The following is a description of a gene set: species: Homo sapiens Human Gene Set: GSE21774_CD62L_POS_CD56_DIM_VS_CD62L_NEG_CD56_DIM_NK_CELL_DN Human Natural Killer (NK) cells comprise two main subsets, CD56bright and CD56dim cells, that differ in function, phenotype and tissue localization. To further dissect the heterogeneity of CD56dim cells, we have performed transcriptome analysis and functional ex vivo characterization of human NK cell subsets according to the expression of markers related to differentiation, migration or competence. Here, we show for the first time that the ability to respond to cytokines or to activating receptors is mutually exclusive in almost all NK cells with the exception of CD56dim CD62L+ cells. Indeed, only these cells combine the ability to produce interferon (IFN)-gamma after cytokines and proliferate in vivo during viral infection with the capacity to kill and produce cytokines upon engagement of activating receptors. Therefore, CD56dim CD62L+ cells represent a unique subset of polyfunctional NK cells. Ex vivo analysis of their function, phenotype, telomere length, frequencies during ageing as well as transfer experiments of NK cell subsets into immunodeficient mice suggest that CD56dim CD62L+ cells represent an intermediate stage of NK cell maturation, which after restimulation can accomplish multiple tasks and further develop into terminally differentiated effectors. Genes down-regulated in SELL dim NK cells: NCAM1+ versus NCAM1-. from publication Juelke K, Killig M, Luetke-Eversloh M, Parente E, Gruen J, Morandi B, Ferlazzo G, Thiel A, Schmitt-Knosalla I, Romagnani C (PMID 20505160), and this is the list of marker genes: ELANE, S100A11, OLR1, EXTL1, TDRD9, EXOSC5, NCF1, TOR3A, MBOAT1, DEUP1 (NCBI Gene Id 159989), PI16, ANXA3, MRGPRF, SPNS3, LRG1, SRP68, SNTB1, TBC1D2, ATP6V0C, TRIM45, KRTAP11-1, CDS1, C19orf38, CCR2, GRIA3, STX7, UBTD1, NAALADL2, H6PD, DDO, TREM1, MRAP, DAAM2, CPVL, SPTAN1, RAB11FIP4, GADD45B, RNF185 (ring finger protein 185), ENO1, COA7, SLC22A4, FES, TRPC7, C1orf141, CIMAP1A, FGFR4, POLR1G, SELENOM, TTYH1, GLRX, EGLN3, MMP8, TYROBP, DAB2, NCALD, DDR2, CABP5, MGST2, SIPA1L2, DUSP9, PRMT8, MXRA7, COL19A1, S1PR2, FGL2, TBRG4, CRYBA2, TTLL6, AANAT, TAFA1, GP2, FCGR2A, MZB1, PLP1, DMKN, CALR, KCNQ3, SATL1 (spermidine/spermine N1-acetyl transferase like 1), MRPL41, HRAS, ALLC, NECAB1, SELL, CFB, KIFC3, BHLHA15, LCN2, ATP8B4, IL12RB2, CHRNA4, MYDGF, HSD11B1, C16orf86, CELSR3, IGSF6, CD52, LDHB, SIGLEC10, HERPUD1, TMED3, POU2F2, TAGLN, GPR160, CD14, CTSG, HTR1F, ALAS1, RPS6KA2 (NCBI Gene Id 6196), SPI1, ACRV1, HP, COL5A3, DNAJC30, PGK1 (phosphoglycerate kinase 1), SAT2, ADAM15, SH2B2, MCEMP1, SLC25A25, GJB5, SPIRE2, FANCC, WNT7B, RASGRP2, SNX18, BCAS1, CPNE5, PHGDH, TEX2, GALNT3, GRIP2, MAP1A, MANBA, CEP128, LYG1, CA12, SERPINA12, RGS4, SHMT1, COL26A1, SPTBN2, OR5D18, PTGER2, FAM114A1, MSRB1, ALDOA, ARID5B, TUBB6, TAS2R4, HCRTR1, SSTR5, IDH1, CXCR2 (NCBI Gene Id 3579), GATAD2A, EDEM1, OPRL1, CCR1, NEU1 (neuraminidase 1), ERLIN1 (ER lipid raft associated 1), SMDT1, ZNF593, LRP1, MS4A3, IL1A, ARHGDIB, FCGR2B, VANGL1, B4GALNT1, GORASP2, PGAM1, PLCXD2, SLC25A18, CHCHD10, IRF8 (interferon regulatory factor 8), SOWAHC, PPM1N, GFRA1, ATP5MG, FUZ, TSPO, VGLL1, NRP1, DUOX1, KIF17, CSF2RA, PLOD3, CLEC7A, SGCG, TNFAIP8L1, SPSB4, LY86, GLA, GJB2, RAB34 (RAB34, member RAS oncogene family), NCF4, CFAP65, TXNDC11, MTUS1, LIPI